Given this list of marker genes Dnaja1, Uba52, Hspa1a, Hspa8, Hspa1b, Tsc22d3, Dnajb1, here is a description of the gene set: studied in species Mus musculus from publication Cui A, Huang T, Li S, Ma A, Pérez JL, Sander C, Keskin DB, Wu CJ, Fraenkel E, Hacohen N (PMID 38057668) Cytokines mediate cell-cell communication in the immune system and represent important therapeutic targets. A myriad of studies have highlighted their central role in immune function, yet we lack a global view of the cellular responses of each immune cell type to each cytokine. To address this gap, the authors created the Immune Dictionary, a compendium of single-cell transcriptomic profiles of more than 17 immune cell types in response to each of 86 cytokines (>1,400 cytokine-cell type combinations) in mouse lymph nodes in vivo. A cytokine-centric view of the dictionary revealed that most cytokines induce highly cell-type-specific responses. For example, the inflammatory cytokine interleukin-1β induces distinct gene programmes in almost every cell type. A cell-type-centric view of the dictionary identified more than 66 cytokine-driven cellular polarization states across immune cell types, including previously uncharacterized states such as an interleukin-18-induced polyfunctional natural killer cell state. Mouse Gene Set: CUI_T_CELL_CD4_IL1RA_RESPONSE_DN Genes negatively differentially expressed in cell type: CD4+ T cell upon treatment with cytokine: IL-1Ra in mouse lymph nodes in vivo.